The following is a description of a gene set: Cancer cells possess traits reminiscent of those ascribed to normal stem cells. It is unclear, however, whether these phenotypic similarities reflect the activity of common molecular pathways. Here, we analyze the enrichment patterns of gene sets associated with embryonic stem (ES) cell identity in the expression profiles of various human tumor types. We find that histologically poorly differentiated tumors show preferential overexpression of genes normally enriched in ES cells, combined with preferential repression of Polycomb-regulated genes. Moreover, activation targets of Nanog, Oct4, Sox2 and c-Myc are more frequently overexpressed in poorly differentiated tumors than in well-differentiated tumors. In breast cancers, this ES-like signature is associated with high-grade estrogen receptor (ER)-negative tumors, often of the basal-like subtype, and with poor clinical outcome. The ES signature is also present in poorly differentiated glioblastomas and bladder carcinomas. We identify a subset of ES cell-associated transcription regulators that are highly expressed in poorly differentiated tumors. Our results reveal a previously unknown link between genes associated with ES cell identity and the histopathological traits of tumors and support the possibility that these genes contribute to stem cell-like phenotypes shown by many tumors. studied in species Homo sapiens Human Gene Set: BENPORATH_PROLIFERATION from publication Ben-Porath I, Thomson MW, Carey VJ, Ge R, Bell GW, Regev A, Weinberg RA (PMID 18443585) Set 'Proliferation Cluster': genes defined in human breast tumor expression data., and this is the list of marker genes: PSMA3, SNRPG (small nuclear ribonucleoprotein polypeptide G), LGALS8, MTFR2, MCM2, RAD54L, MAGOHB, SPAG5, NCS1 (NCBI Gene Id 23413), CTPS1, RAD51AP1, SRPK1, PRIM2, PRPF18, CENPU, UGGT1 (NCBI Gene Id 56886, UDP-glucose glycoprotein glucosyltransferase 1), CDKN3, HIKESHI, AURKA, CENPE, RAD51, DEK (NCBI Gene Id 7913), H2AZ2 (H2A.Z variant histone 2), PSMB4, GART, PLAAT1, MRPL9, GNB4 (NCBI Gene Id 59345), CENPM, CDK1, ATAD2, DCUN1D5, PKMYT1, BUB1, SLC25A5, BIRC5, MYBL2, RFC4, SUV39H2, PDCD10, AGFG1, APOBEC3B, PFDN2, HDAC2, ARF1, MCM3, TMSB10, CENPA, NDC80, GPSM2, S100A11, RBM8A, CNIH4, FANCA, DTL, PARP1, CKS1B, FAM3C (NCBI Gene Id 10447), DAP3, RACGAP1, CDC123, TMEM14A, ILF2, TTK, DBF4, SEM1, KPNA2, CHAF1B, PBK, ANLN, RRAGD, RDX, NFE2L3, TP53BP2, GARS1, COX5A, PRC1, GDI2, H2AZ1, PROSER1, CMSS1, DTYMK, TOP2A, CDCA5 (NCBI Gene Id 256676), IDH2, CCNB2, ASF1A, CYRIB, SMAD2, HSPA14, CEBPG, NCAPG, S100A9, CDCA7, EXO1, PTS, MARCO, CMC2, GGCT, SNRPD1, UBE2T, CENPN, NUF2, NEK2, MSH2, CDT1, CENPF, NUDT5, TYMS, KDELR2, A1BG, FANCE, PDCD5, EZH2 (NCBI Gene Id 392834), KNSTRN, ASPM, RRM2, CSTB, LRP8, CKS2, TFRC, CSNK1G1, PPIL1, AVL9, DESI2, WDR26, MAD2L1, EMC8, PDSS1, CTSV, RANBP1, PURB, PTTG1, A2M, CSE1L, PCNA (NCBI Gene Id 5111), FIRRM, NDUFB5, LBR, NMI, UTP25, RIT1, MND1, STMN1, GINS3, GTPBP4, ANKRD27